The following is a description of a gene set: Mouse Gene Set: REACTOME_SIGNALING_BY_TGF_BETA_RECEPTOR_COMPLEX species: Mus musculus Signaling by TGF-beta Receptor Complex, and this is the list of marker genes: Ccnc, Wwtr1, Sp1 (NCBI Gene Id 68485), Hdac1, Smad2, Men1, Fkbp1a, Smurf2, Cdk8, Rnf111, Cdk9, Stub1, Smad7, Bambi (NCBI Gene Id 68010), Zfyve9, Itga8, Smurf1, Furin, Tgfbr2, E2f4, Atp1b4 (ATPase Na+/K+ transporting, beta 4 polypeptide), Mapk1, Prkcz, Ltbp2, Ncor2, Tgif1, Ltbp1, Ube2m, Ubb (NCBI Gene Id 22187), Ccnt2, F11r, Ski, Ubc, Tgfb1, Itgb3, Tgfbr1, Usp9x, Rbl1, Mapk3, Ccnt1, Smad4, Strap (NCBI Gene Id 97291), Rhoa, Uba52, Cgn, Rps27a, Pard3, Smad3, Arhgef18 (Rho/Rac guanine nucleotide exchange factor 18), Cbl, Skil, Nedd8, E2f5, Mtmr4, Ltbp4, Pmepa1, Ube2d3, Ppm1a, Itgav, Ccnk, Fbn1, Pard6a, Tgfb2, Tgif2, Itgb1, Ltbp3, Tgfb3, Tgfbr3, Itgb6, Tfdp1, Parp1 (poly (ADP-ribose) polymerase family, member 1), Uba52rt, Ube2d1, Itgb8, Nedd4l